The following is a description of a gene set: Human Gene Set: REACTOME_PLATELET_HOMEOSTASIS studied in species Homo sapiens Platelet homeostasis, and this is the list of marker genes: SRI, PDE11A, IRAG1, PRKG2, ATP2B3, TRPC7, PPP2R5E, KCNMB2, PDE9A, GUCY1A2, PLA2G4A, PDE1B, MAPK14, NOS1 (NCBI Gene Id 4842), PPP2R1B, PDE5A, ATP2B4, GNB1, PECAM1, APOB, GNG5, GUCY1A1, P2RX4, GNG12, PTGIR, P2RX6, P2RX1, ATP2A1, GNB4, ORAI2, PPP2CB, LRP8, NOS3, ITPR2, P2RX7, PPP2R5B, GNG13, ATP2B1, GNG4, KCNMB1, PDE2A, PTPN6 (protein tyrosine phosphatase non-receptor type 6), P2RX2, PTPN11, GNB2, PPP2CA, PPP2R5A, GNAS, GNB3, ITPR3 (inositol 1,4,5-trisphosphate receptor type 3), PPP2R5C, STIM1, NOS2, PPP2R1A, CALM1, GNG10, KCNMA1 (NCBI Gene Id 3778), ATP2A2, ATP2A3, PDE1A, TRPC6, P2RX5, TRPC3, GNG3, SLC8A1, KCNMB3, PAFAH2, GNGT2, P2RX3, PPP2R5D, ATP2B2, GNGT1, SLC8A2, GUCY1B1, GNG7, ITPR1, ORAI1, FGR, PRKG1, GNG2, PDE10A, GNG11, GNG8, KCNMB4, SLC8A3, GNB5